The following is a description of a gene set: studied in species Mus musculus Mouse Gene Set: GOMF_HYDROLASE_ACTIVITY_ACTING_ON_GLYCOSYL_BONDS Catalysis of the hydrolysis of any glycosyl bond., and this is the list of marker genes: Idua, Cd38, Dnph1, Lyg1, Gba1, Adprh, Sis, Cemip, Naglu, Pgghg, Tlr13, Gbe1, Mutyh, Amy2a3, Tlr2 (NCBI Gene Id 24088), Lctl, Neu2, Nthl1, Lct, Il1rapl1, Neu3, Spam1, Treh, Chil6, Cln5, Man2c1, Chia1, Chit1, Klb, Edem2, Glb1l3, Neil3, Manea, Agl, Lyg2, Hyal2 (NCBI Gene Id 15587), Il1r1, Art2b, Sarm1, Lyz3, Lyz2, Gne, Lyzl4, Gba2, Hyal3 (NCBI Gene Id 235600), Mgam2-ps, Manba, Lalba, Kl, Amy2a5, Hyal4, Man2b1, Glb1, Maneal, Glb1l, Il1rl1, Hyal5, Lyz1, Hexa (NCBI Gene Id 15211), Macrod1, Nagpa, Edem1, Ganc, Adprhl1, Man1a, Neil2, Fuca2 (fucosidase, alpha-L- 2, plasma), Edem3, Chil4, Otogl, Bst1, Tlr4, Gusb, Gm1110, Mgam, Il18r1, Lyzl1, Dctd, Mbd4, Smpd1, Engase, Parg, Gm2a, Mpg, Gaa, Art2a, Lyzl6, Man2b2, Tlr6, Ugt1a6a, Tdg, Ctbs, Smug1, Abhd10 (NCBI Gene Id 213012), Amy2a2 (amylase 2a2), Chil3, Naga, Tlr1, Tdg-ps, Neil1, Myorg, Hpse, Tlr11, Man1c1 (NCBI Gene Id 230815), Cemip2, Amy1, Man1b1, Neu1, Pcna, Ogg1, Tlr12, Adprs, Chil5, Fuca1, Amy2a1, Ovgp1, Man2a2, Spaca5, Neu4, Hexd, Mogs, Macrod2, Chi3l1, Il1rap, Il18rap, Man2a1, Ung, Galc, Hyal1, Oga, Ganab, Il1rl2, Spaca3, Hpse2, Oard1, Otog, Man1a2, Smpdl3b, Hexb (NCBI Gene Id 15212), Amy2a4, Gla, Glb1l2, Il1rapl2